Given this list of marker genes CDSN, LPIN2, ANKRD17, ATP13A4, LAP3, NEK8, C3orf80, CZIB (CXXC motif containing zinc binding protein), ZEB2, WDHD1, DTYMK, OIP5, HAUS3, MBNL1, NCAPG, C12orf75, MEMO1, WNT9B, GEMIN6, EPHX1, HNRNPAB, MYCBP2, FAM110C, NANS, WDR76, KIF2C, VWA3B, CD96, CACNA1G, ATP8A1, NUP85, MEIOC, NUP43, LGALS7, REXO5, SLC43A3, IFIH1, ENO3, KDR, SLC43A1, OOEP, CUL2, CENPK, STC1, SAMD9L, TIMM8B (NCBI Gene Id 91900), ARL6IP1, NUP155, RESP18, MICU2, PUS10, LYAR, SLC25A3, HSPBP1, DRC1, NOP16 (NOP16 nucleolar protein), SLC39A3, RPS6KL1, TNFSF10, SLC35C2, CLXN, SETDB2, MLLT1, ALDH4A1, PARP8, INPP1, NDUFS7, FFAR4, HSD11B1, PLA2G4F, PYCARD, MELK, PENK (NCBI Gene Id 5179), ERCC6L, HBG2, KIFC1, FAM111A, CNIH4, TMEM243, CHCHD10, TGIF2, CKAP2L, CLCNKB, HPF1, IMPA1, HDAC1, FUT9, LTV1, ZCRB1, RAB11FIP4, LRPPRC, BUB3, SYTL4, RAD54B, GFI1B, FASTKD5, STBD1, LCN9 (NCBI Gene Id 392399), ERAP1, NUP160, HNRNPA3 (heterogeneous nuclear ribonucleoprotein A3), CCDC158, RAB3IP, FAM204A, TAMALIN, CHAF1B, IQCA1, HS6ST3, TMCC3, LIPF, EIF3L, DDX56, C16orf74, SLC9A5, CDC45, TMEM39A, NCAPD2, DUT, ADAMTS6, ABLIM3, EIF3I, MTFP1, NINJ1, SET, COQ6, ZZZ3, CCND2, POLE4, NOP10, RBBP7, CD300LB, HELLS, LIN28B, DCLK2, ANKRD44, CLRN3 (NCBI Gene Id 119467), SLIRP, CNTNAP1, CLDN16, TEDC1, EPB41L4A, HMCES, BMI1, BTG3, OPCML, FLYWCH2, RAD51AP1, B3GAT2, DDX51, YWHAB, VRK2, CENPE, NPTX1, SRFBP1, NR1H4, SMARCB1, DUSP12, MRPL39, IFI44L, ELF5, USP39, CNTN4, MYL4, TBC1D7, PDZRN3, DIS3, CBX5, RAD54L, SLC23A3, SCIN, RECQL4, ADGRE5, DNMT1, IFITM2, GTF3C5, MTM1, LGALS9B, MYO1E, ATP1A2, PDE7A, PRSS36, CDC20, IFNG, RMDN3, NPM3, PDSS2, TBC1D4, SAT2, MZB1, GLE1, AGR3, RTEL1, NMI, TK1, DHFR, NEK2, BCKDHB, KAZN, HCAR1, here is a description of the gene set: Genes up-regulated in monocytes (3h): untreated versus M. tuberculosis 19 kDa lipopeptide. In innate immune responses, activation of Toll-like receptors (TLRs) triggers direct antimicrobial activity against intracellular bacteria, which in murine, but not human, monocytes and macrophages is mediated principally by nitric oxide. We report here that TLR activation of human macrophages up-regulated expression of the vitamin D receptor and the vitamin D-1-hydroxylase genes, leading to induction of the antimicrobial peptide cathelicidin and killing of intracellular Mycobacterium tuberculosis. We also observed that sera from African-American individuals, known to have increased susceptibility to tuberculosis, had low 25-hydroxyvitamin D and were inefficient in supporting cathelicidin messenger RNA induction. These data support a link between TLRs and vitamin D-mediated innate immunity and suggest that differences in ability of human populations to produce vitamin D may contribute to susceptibility to microbial infection. from publication Liu PT, Stenger S, Li H, Wenzel L, Tan BH, Krutzik SR, Ochoa MT, Schauber J, Wu K, Meinken C, Kamen DL, Wagner M, Bals R, Steinmeyer A, Zügel U, Gallo RL, Eisenberg D, Hewison M, Hollis BW, Adams JS, Bloom BR, Modlin RL (PMID 16497887) studied in species Homo sapiens Human Gene Set: GSE8921_UNSTIM_VS_TLR1_2_STIM_MONOCYTE_3H_UP